Given this list of marker genes VPS33B, RPGRIP1L, INPP5E, TMEM67, ERCC4, RFX6, ZIC3, CLDN1, CC2D2A, LONP1, GATA6 (NCBI Gene Id 2627), TCTN3, here is a description of the gene set: Atresia of the biliary tree. studied in species Homo sapiens Human Gene Set: HP_BILIARY_ATRESIA Biliary atresia